The following is a description of a gene set: studied in species Homo sapiens The chemical reactions and pathways involving polyketides, any of a diverse group of natural products synthesized via linear poly-beta-ketones, which are themselves formed by repetitive head-to-tail addition of acetyl (or substituted acetyl) units indirectly derived from acetate (or a substituted acetate) by a mechanism similar to that for fatty acid biosynthesis but without the intermediate reductive steps. Human Gene Set: GOBP_POLYKETIDE_METABOLIC_PROCESS, and this is the list of marker genes: AKR1C3, AKR1B1, AKR1C2, AKR1A1, AKR1C1, AKR7A2, AKR1C4 (NCBI Gene Id 1109), CBR4, SULT1C4, AKR1B10